The following is a description of a gene set: Reactome Pathway: Glucagon-like Peptide-1 (GLP1) regulates insulin secretion part of: Regulation of insulin secretion Glucagon-like Peptide-1 (GLP-1) is secreted by L-cells in the intestine in response to glucose and fatty acids. GLP-1 circulates to the beta cells of the pancreas where it binds a G-protein coupled receptor, GLP-1R, on the plasma membrane. The binding activates the heterotrimeric G-protein G(s), causing the alpha subunit of G(s) to exchange GDP for GTP and dissociate from the beta and gamma subunits.<br>The activated G(s) alpha subunit interacts with Adenylyl Cyclase VIII (Adenylate Cyclase VIII, AC VIII) and activates AC VIII to produce cyclic AMP (cAMP). cAMP then has two effects: 1) cAMP activates Protein Kinase A (PKA), and 2) cAMP activates Epac1 and Epac2, two guanyl nucleotide exchange factors.<br>Binding of cAMP to PKA causes the catalytic subunits of PKA to dissociate from the regulatory subunits and become an active kinase. PKA is known to enhance insulin secretion by closing ATP-sensitive potassium channels, closing voltage-gated potassium channels, releasing calcium from the endoplasmic reticulum, and affecting insulin secretory granules. The exact mechanisms for PKA's action are not fully known. After prolonged increases in cAMP, PKA translocates to the nucleus where it regulates the PDX-1 and CREB transcription factors, activating transcription of the insulin gene.<br>cAMP produced by AC VIII also activates Epac1 and Epac2, which catalyze the exchange of GTP for GDP on G-proteins, notably Rap1A. Rap1A regulates insulin secretory granules and is believed to activate the Raf/MEK/ERK mitogenic pathway leading to proliferation of beta cells. The Epac proteins also interact with RYR calcium channels on the endoplasmic reticulum, the SUR1 subunits of ATP-sensitive potassium channels, and the Piccolo:Rim2 calcium sensor at the plasma membrane. species: Homo sapiens, and this is the list of marker genes: GNG10, ADCY6, KCNC2, PRKAR1A, ITPR3, PRKAR1B, GNG2, GNG7, GNG5, RAP1A, RAPGEF4, ITPR2, GNB5, GNG4, GNG3, GCG, GNG12, GNAS, GLP1R, GNB1, IQGAP1, KCNS3, PRKAR2A, RAPGEF3, GNG13, GNB4, PRKACG, ADCY5 (NCBI Gene Id 255218), ITPR1, PRKACB, ADCY8, PRKAR2B, GNB2, AKAP5, PRKACA, GNG8, KCNG2, GNGT1, GNG11, GNB3, GNGT2, KCNB1